Given this list of marker genes FANCD2, HACE1, BMPR1A, TMPRSS6, FANCC (NCBI Gene Id 2176), MYCN, ALK, FANCA, LIN28B, ALAS2, LMO1, SMAD4, ENG, FANCE, PHOX2B, here is a description of the gene set: Human Gene Set: HP_ANEMIC_PALLOR A type of pallor that is secondary to the presence of anemia. Anemic pallor studied in species Homo sapiens